The following is a description of a gene set: Mouse Gene Set: GOBP_PLASMA_LIPOPROTEIN_PARTICLE_CLEARANCE The process in which a lipoprotein particle is removed from the blood via receptor-mediated endocytosis and its constituent parts degraded. species: Mus musculus, and this is the list of marker genes: Khsrp, Lipa, Dgat2, Vldlr, Commd1, Ldlrap1, Apoe, Pcsk9, Trem2, Msr1, Cnpy2, Gpld1, Ehd1 (EH-domain containing 1), Apom, Apob, Mylip, Scarb1, Anxa2, Lipg, Crp, Lrpap1, Gpihbp1, Hnrnpk, Apoc2l, Abcc8 (ATP-binding cassette, sub-family C member 8), Apoc3, Apoa2, Washc1, Ces1g, Adipoq (NCBI Gene Id 11450), Ldlr, Csk, Lipc, Apoc2, Cd36, Nr1h4, Il19, Lmf1, Apoc1